Given this list of marker genes Dclre1c, Far1, Eny2, Cnn3, Qser1, Man2a1, Mtm1, Nr3c1, Slc17a5, Slc66a3, Marchf8, Col4a1, Pter, Nfatc2, Kcnk2, Pcdh8, Arf2, Fhip1a, Tmem8b, Mapk14, Galnt10, Tacc1, Sh3kbp1 (NCBI Gene Id 80469), Rhbdf1, Crebrf, Pabpc4l, Adgre1, Chst1, Akt1s1, Mapk4, Sugt1, Prtg, Dhrs1, Sft2d2, Entpd5, Fermt2, Abhd5, Lrrc57, Myo1e, Upf3b, Nfib, Uba6, Pttg1ip, Thap2, Pik3c2a, Rala (NCBI Gene Id 80577), Snx18, Hebp2, Hectd2, Hlf, Traf3, Dact1, Trp53inp1, Ryr3, Selenoi, Lrig1, Acadvl, Vps4b, Galc, Vat1l, Ets1, Sema6d, Osbpl8, Ctnnd1, Phex, Gsn, Sgk1, Mgat4a, Gzf1, Tjp2, Med12l, Morc4, Acadsb, Med26, Fbxo38, Rnf135, Gria4, Arsk, Stat3, Osbpl3, Cpt1a, Ptpn12, Cspp1, B4galt1, Klf6, Adcy1, Alx1, Smarcad1, Rnpepl1, Ifit1bl2, Cbx2, Tfap4, Sumf1 (sulfatase modifying factor 1), Ctdsp2, Elk3, Fzd4, Adgrg5, Rpusd1, Ptbp3 (NCBI Gene Id 99962), Arfgef3, Ranbp10, Efcab2, Plekhm3, Pemt, Cc2d1b, Axin1, Gga2, Gria3, Emc3, Ak2, Pde4b, Ror2 (receptor tyrosine kinase-like orphan receptor 2), Sox8, Tshz1, Ptpn4, Dusp15, Glis2, Ginm1, Papolg (NCBI Gene Id 216578), Clock, Ap1m2, Gpt2, Cgn, Yipf6, Itpr3 (inositol 1,4,5-triphosphate receptor 3), Magt1, Pdcd6, Slc39a9, Rcor1, Usp24, Apbb2, Eif1ad, Hipk1, Hdac4, Pecr, Stk26, Nol4 (nucleolar protein 4), Scamp2, Septin10, Cep135, Acss1, Rab10, Rsrc2, Ppp1r3d, Cdh9, Lpin1, Hivep3 (human immunodeficiency virus type I enhancer binding protein 3), Atxn1l, Tor3a, P4ha1, Fnbp1 (NCBI Gene Id 70068), Kif2a, Lcp1, Fstl5, Fndc3b, Fam171a1, Slc26a2, Gltp, Capn2, Usp14, Gpam, Rock2, Ctdsp1, Smurf2, Cd164, Suco, Prrx1, Cers2, Myadm, Rassf5, Usp45, Dll4, Chuk, Wdr46, Fsd1l, Gpatch8 (NCBI Gene Id 71417), Mocs1, Tead1, Gstt3, Rarg, Sema6a, Rragd, Ddx3x, Tasp1, Casq2, Pgrmc2, Steap3, Rfx3, Anxa11, Plxna3, Sgms1, Lingo3, Arih1, Lemd2, Wdfy3 (WD repeat and FYVE domain containing 3), Tub, Poglut1, Plekhf2, Pam, Eci2, Kif3a, Vat1, Gpr37, Zmat3, Kif26a, Hic1, Smox, Rab3d, Foxq1, Sos1, Tmed1, Usp1, Tpst2, Sh3pxd2a, Twsg1, Lmf2, Lrrc1, Cdk13, Alg2, Serinc2, Ern1, Anxa7, Orc2, Sdf2l1, Mob1b, Dipk2a, Pip4k2c, Ctns, Iffo2 (intermediate filament family orphan 2), Atp7a, Ccdc89, Ccsap, Prkd1, Rhou, Cmtr2, Prr32, Ccdc177, Arfgef2, Natd1, Tmem134, Slitrk4, Slc1a4 (solute carrier family 1 (glutamate/neutral amino acid transporter), member 4), AI593442, Ryr2, Niban2, Epn2, Ankrd27, Prpf40a, Ppm1f, Ccdc121rt1, Usp38, Kank1, Susd6, Wasf2, Mkx, Smco4, Relch, Palld, Raver1, Itprip, Dmrta1, Fkbp1b, Itga7 (integrin alpha 7), Pan3, Cyb5a, Sos2, Hipk3, Lonrf1, Wtap, Pim1, Map3k2, Ube4a, Ppp1r13l, Yme1l1, Ccdc86, Tmem104 (NCBI Gene Id 320534), Jakmip3, Dgat2, Hadh, Kat7, Enpp4, Abhd10, Phka1, Raph1, Myzap, Zfp503, Tmco3, Nr3c2, Scd1, Rbm24, Lclat1, Mef2a, Qki, Lpp, Ogfod3, Shroom4, Ppfibp2, Myh9, Rhbdd1, Sestd1, Vamp3, Sppl2a, Rnf128 (NCBI Gene Id 66889), G3bp1, Iqgap2, Septin9, Kcnk10, Rwdd4a, Fpgs, Bmp6, Nr4a1, Plekhh2, Mylk4, Ice2, Frmd4b, Eya2, Manbal, Edem1 (NCBI Gene Id 232324), Esyt2, Ptprj, Dennd1b, Rlim (ring finger protein, LIM domain interacting), Rapgef1, Tsku, Fxr1, Litaf, Capn6 (calpain 6), Prr14l, Clmn, Pcsk1n, Myrip, Wdr81, Slc9a2, Tnrc6b, Rnf19a, Efna5, Qsox1, Rfx4, Lnpk, L2hgdh, Plscr3, Cxadr, Xkr8, Wipf3 (NCBI Gene Id 330319), Zbed4, Iqgap1, Pard3, Wipf1, Mtr, Ttl, Glce, Pim3, Rpia, Syt14, Plod3, Svip, Bcl7a, Stt3a, Ptbp2, Antxr2, Ovol2, Sgpl1, Myo10, Oaf, Cdh4, Ptpn11, Pgf, Furin, Neurl1b, Cflar, Spty2d1, C9orf72, Lims1, Aff1, Vps37c, Slco5a1, Eea1, Snai2, Tarbp1, Lamc1 (NCBI Gene Id 226519), Slc40a1, Eml6, Phactr2, Trib3, Shq1, Fam177a2, Arpc1b, Cotl1, Bmpr1a, Mdk, Fam219b, Slc35g1, Crat, Gria2, Fam177a, Bach2, 2510039O18Rik, Atad2b, Ralbp1, Cpd, Inf2, C1ra, Rhoq, Gli3, Epha3, Prr5l, Atf7, Apba3, Slc50a1, Ece1, Lemd3, Folr1, Rnf144a, Gcdh, Calcoco1, Mitf, Rock1, Cmpk1, Stk38, Parp16, Kdm5a, Slc12a9, Cdon, Eps8, Apln (apelin), Tnfrsf22, Rhog, Tmem87b, Irf2bp2, Marveld1, Limch1, Fadd, Paqr9, Srek1, Usp2, Tmod1, Slitrk6, Dmrt1, Ints6l, Jam2, Cadps, Ptpn9, Serp1, Sp1 (trans-acting transcription factor 1), Btbd10, Pabir2, Osbpl11, Polr1b, Rad17, Nfatc1, Nrp1, Myrf, Nat8l, Mid1ip1, Ahr, Gata6, Slc30a10, Gmfb, Tpd52l2, Fam78a, Chp1, Cnep1r1, Rasgef1a, Abcc4, Usp32, Nek9, Dlx3, Gnai1 (G protein subunit alpha i1), E130308A19Rik, Wrn, Hadha, Atl3, Unc119b, Usp30, Top3a, Six4, Nras, Spindoc, Flot2, Ppl, Minar1 (membrane integral NOTCH2 associated receptor 1), Srsf6, Gmcl1, Egr1, Eya1, Nsun2 (NOL1/NOP2/Sun domain family member 2), Tnfrsf23, Rab34, 0610030E20Rik, Nfic, Bmpr1b, Plekha5, Cdk6 (cyclin dependent kinase 6), Zmpste24, Tfdp2, Ptprz1, Osbp, Rsu1, Zfp608, Jag1, Prlr, Slc35a4, Dnajc1, Suclg2, Sgcz (sarcoglycan zeta), Plekhh1, Hivep2, Rffl, Rela, Vps35, Aldh9a1, G2e3, Chsy1, Elk4, Arg2, Kcnq5, Irf2bpl, Hs1bp3, Lrrc58, Crtc3, Piezo2, Cav1, Grb2, Itgb1, Lmbrd1, Snta1, Flrt3, Papss2, Zdhhc3, Tet1, Nme4, Sntb2, Sh2b3, Slc10a7, Ddx6, Ascc2, Znrf3, Ammecr1, Alpk3, Hivep1, Zfp36l1, Abca9, Mdga2, Rbms3, Cebpa, Sgpp1, Lrrfip2, Dennd6a, Evi5, Slc30a7, Ntrk2, Foxc1, Frmd8, Slit1, Fam81a, Nipa1, Wipf2, Ildr2, Mvp, Rnf216, Kif26b, Nfix, Sigmar1, Yeats2, Tmem109, Fa2h, Ptbp1, Xrcc6, Tsc22d4, Fcho2, Slitrk3, Gpd2, Sh3rf1, Shkbp1 (Sh3kbp1 binding protein 1), Tcl1b4, Rrbp1, Naa15 (N(alpha)-acetyltransferase 15, NatA auxiliary subunit), Shc1, Pkn2, Myh10, Cask, Rcbtb2, Miga1, Zfp706, Slc31a2, Suv39h2, Plxnb2, Prkg1, Srgap1, Galnt4, Amotl1, Mylip, Tpcn2, Elovl5, Dlx5, Rab11fip1, Tfeb, Plekhf1, Cnksr3, Jade1, Spopfm2, Alkal1, Pskh1, Ppp1r3b, Ldlrap1, Calu, Sertad4, Ipo8, Pml, Hdac9, Slc16a1, Fam53b, Nap1l5, Slc7a14, Tor1aip2, Ctdspl, Cand2, Vim, E2f5, Mtmr10, Sptlc2, Ryr1, Chic1, Fchsd2, Prkag2, 2310079G19Rik (NCBI Gene Id 69699), Ppp2r1b, Bloc1s6, Spopl, Anks1, Slc27a1, Zfp36l2, here is a description of the gene set: from publication Chen Y, Wang X (PMID 31504780) species: Mus musculus Genes predicted to be targets of miRBase v22 microRNA mmu_miR_124_3p in miRDB v6.0 with MirTarget v4 prediction scores > 80 (high confidence targets). Mouse Gene Set: MIR_124_3P